The following is a description of a gene set: studied in species Mus musculus from publication Tabula Muris Consortium (PMID 32669714) Mouse Gene Set: TABULA_MURIS_SENIS_HEART_AND_AORTA_CARDIOMYOCYTE_AGEING, and this is the list of marker genes: Use1, Atp5if1, Rpl18a, Rpl39, Eef1a1, Myl12a, Ankrd1, Ubb, Mt2, Rps3, Rpl21, Rpl19, Timm23, Flot1, Slc25a4, Myl1, Rps25, Rpl13a, Oaz1, Myoz2, Rps20, Vapa, Cox19, Rpl24, Rpl32, Rnf7, 9330158H04Rik, Fhl1, Gltp, Morf4l1, Mpc1, Snx3, Acadl, Gnas, Map1lc3b, Junb, Rps13, Rps26, Pdcd5, Mt1, Dstn, Smpx, Vdac1, H3f3a, Tmed3, Mir703, Park7, Nme2, Rpl6, Gabarap, Aurkaip1, Ndufa10, Rps15a-ps6, Rpl36a, Rps11, H2-D1, Eif4b, Eif1, S100a6, Cox17, Rpl17, Rpl31-ps12 (NCBI Gene Id 670381), Rpl23, Ftl1, Atp5pd, Rpl23a, Rpl12, Rps5, Ufc1, Pdlim7, Gapdh, Rpl3, Rps2, Psmb1 (proteasome (prosome, macropain) subunit, beta type 1), Phyh, Rpl7a, Igfbp7, Morf4l1-ps1, Btg2, Rps3a1, Gm5069, Rps9, Rps23, Rplp0, Rpl7, Gpx4, Rps4x, Rpl27a, Rpl15, Pnrc1, Sumo2, Mrpl30, Hspb1, Rpl10, Tpm1, Aldoa, Rps24, Efhd2, Arf4, Serpinb6a, Rpl4, Fth1, Cfl2, Atp5mc2 (ATP synthase membrane subunit c locus 2), Selenok, Rbm3, Rpl8, Rps6 (ribosomal protein S6), Vps72, Jun, Cox7b, Csrp3, Rps12 (ribosomal protein S12)